Given this list of marker genes AIDA, DDX60, TYMP, DDX47, GTF2E2, SMC3, C1S, PSMB2, IDO1, RHOBTB3, HLA-DQB1, IL32, CFB, GBP2, P2RY6, PAK1, CHD9, RCN1, USP15, PSMA2 (NCBI Gene Id 5683), GVINP1, GUF1, AP3D1, ARF3, PLAAT4, ZFP36L1, ANKMY2, IL10RA, OSBPL11, CYLD, TMSB10, GAS8 (growth arrest specific 8), PSMB8, PSMB10, IFI44, MVP, IFIH1, APOL6 (apolipoprotein L6), STOM, LPGAT1, SERPING1, NOC3L, ISOC1 (NCBI Gene Id 51015), INTS13 (NCBI Gene Id 55726), JAK2, AGPAT5, RHBDF2, GIMAP4, ATG3, TAP2, C1R, CRLF3, BTN3A3, STAT1, CASP4, GBP1, GCLC, GIMAP6, VAMP5, SECTM1, VPS4A, GPN3, GRSF1, CUL1, PSMB9, HLA-DRA, RALB, RSU1, ACTR6, SLC31A1, RNF114, HCP5, FADD, RBBP6, PRPF39, RPAP3, PHF11, PDIA3, MTHFD1, RBM34, UBR2, SEPTIN4, TMEM109, NSMCE4A, TAP1, CDA, MYOF, LAG3, CIITA, TAPBPL, HLA-DPB1, TRPM4, TRAF2, SELL, ASCC3, ERC2, FAS, PSME1, PACRG, LAT2, SP110, SP140L (NCBI Gene Id 93349), SCO2, SP140, TMA16, CETN3, ISG20 (NCBI Gene Id 3669), DIPK1A, CD38, TNFAIP2, TRIM22, ST3GAL5, PSME2, NMI, CAPRIN1, GGPS1, APOL1, AVL9, BIN2, AKAP7, AMBP (NCBI Gene Id 259), CYBC1, FAN1, DNAAF2, DENND1B (DENN domain containing 1B), RBCK1, APOBEC3G, DR1, USP10, HLA-E, MAX, IL15RA, CXCL11, IFI44L, PTGES3, CASP5, BTN2A2, MAT2B, WARS1, TMEM131, SMURF1, IFITM1, PSMA4, RFK, CRYBG1 (crystallin beta-gamma domain containing 1), C5orf15, USP7, C1RL, JADE2, SSPN, CALCOCO2, APOL2, BTN3A1, PLA2G4A, APOL3, FNTA, LGALS3BP, IGFBP4, TRIM5, BTF3P11, LYN, RAD50, RALGDS, BAZ1A, UVRAG, ANK2, RMDN3, THAP11, UCN, CD47, NADK (NCBI Gene Id 65220), SLAMF8, CXCL9, SNTB2, TNFRSF14, NOD2, UTP6, LAP3, DNMT1, INSIG2, IRF7, ERAP2, GUCY1A1, HLA-DRB1, ERAP1, ADGRE5, SPDL1, RTCA (NCBI Gene Id 8634), CD74, HLA-F, MAP3K11, SS18L2, PRPS2, PLEKHO1, PSMC2 (NCBI Gene Id 5701), TUBGCP3, DHX58, FCGR1BP, SMCO4, TNFSF10, here is a description of the gene set: studied in species Homo sapiens Genes down-regulated in comparison of microglia cells 1 h after stimulation with IFNG versus microglia cells 24 h after the stimulation. Microglial cells are resident macrophages in the central nervous system (CNS) and play a pivotal role in the innate and adaptive immune responses against microbial infections. The immune functions of microglia are regulated by a milieu of cytokines including interferon (IFN)-gamma. We here performed a series of experiments to acertain the transcriptional profile of human fetal microglial cells at 1, 6, and 24 h after IFN-gamma treatment. Primary human microglial cells were either untreated or treated with 200u/ml IFN-gamma. Affymetrix U133A chips were utilized. Four different tissue samples (B18, O, W, and Y20) were analyzed at the three time points. from publication Rock RB, Hu S, Deshpande A, Munir S, May BJ, Baker CA, Peterson PK, Kapur V (PMID 16163375) Human Gene Set: GSE1432_1H_VS_24H_IFNG_MICROGLIA_DN